The following is a description of a gene set: Human Gene Set: GOMF_UDP_GLYCOSYLTRANSFERASE_ACTIVITY Catalysis of the transfer of a glycosyl group from a UDP-sugar to a small hydrophobic molecule. studied in species Homo sapiens, and this is the list of marker genes: UGGT2, ALG5, UGT1A5, GALNT11, A3GALT2, B3GNT3, MGAT4D, LALBA, UGCG, UGT1A6, UGT3A1, GALNT1, GALNT6, MGAT4A, GYG2, ALG13, GYG1, B4GALT5, GALNT4 (NCBI Gene Id 8693), PIGA, HAS2, B3GAT1 (beta-1,3-glucuronyltransferase 1), B4GALNT3, LARGE2, COLGALT1, UGT1A10, COLGALT2, UGT1A3, MGAT4B, GALNT16, PIGQ, B3GAT3, LFNG, GLT8D1, UGT2B10, HAS1, B4GALT7, B4GALNT4, EXT1, B3GNTL1, B3GNT6, UGT2B4, GALNT14, MGAT2, POGLUT1, PLOD3, EPM2A, CSGALNACT2, UGT1A9 (NCBI Gene Id 54600), B3GNT7, CHPF2, MGAT5, UGT2B17, B4GALNT2, ABO, B3GALT2, GALNT18, UGT1A8, UGT2B28, GALNT12, HEXA, A4GNT, XXYLT1, UGT3A2, B3GNT4, MGAT5B, GALNTL6, UGT2B15, LARGE1, GALNT8, B3GALNT1, CHSY3, GALNT15, GALNT17, B3GALNT2, B4GALT4, OGT, B3GNT9, CERCAM, HEXB, B4GAT1, MGAT1, EOGT, GALNT5, CHSY1, GYS2, B3GNT5, B3GAT2, GCNT2, MGAT3, GALNT2, UGT1A4, CSGALNACT1, CHPF, MFNG, B3GNT8, GYS1, UGT2A3, GBGT1, GXYLT1, UGT2A1, GCNT7, GALNT9 (NCBI Gene Id 729185), GCNT4, UGT2B7, GALNT10, GCNT1, B3GALT1, EXTL3, B3GALT4, A4GALT, POGLUT3, B3GNT2, GXYLT2, UGT8, EXT2, B3GLCT, B3GALT5, UGT1A7, UGT1A1, XYLT1, PIGP, UGGT1, B4GALT1, GALNT7, RFNG, XYLT2, MGAT4C, HAS3, GALNT3, UGT2B11, B4GALT6, RXYLT1, EXTL2, POMGNT2 (NCBI Gene Id 84892), POGLUT2, EXTL1, UGT2A2, GALNT13, GCNT3, B4GALT3, B4GALNT1, PIGY, POMGNT1, GLT8D2, B4GALT2, B3GALT6